The following is a description of a gene set: Mouse Gene Set: GOBP_COLLAGEN_CATABOLIC_PROCESS The proteolytic chemical reactions and pathways resulting in the breakdown of collagen in the extracellular matrix, usually carried out by proteases secreted by nearby cells. species: Mus musculus, and this is the list of marker genes: Ctsl, Mmp10, Mmp8, Mmp20, Mmp19, Mmp1a, Adam15 (ADAM metallopeptidase domain 15), Prss2, Vsir, Idua, Mmp27 (NCBI Gene Id 234911), Mmp23, Mmp21, Mmp16, Fap, Mmp12, Mrc2, Mmp9, Mmp25, Mmp2, Mmp28, Mmp3, Itgb1, Mmp11, Retreg1, Ctss, Mmp24 (matrix metallopeptidase 24), Mmp14, Ctsb, Mmp15, Mmp1b, Retreg2, Adamts2, Mmp7 (matrix metallopeptidase 7), Prtn3, Ctsk, Retreg3, Mmp17, Pepd, Cst3, Mmp13